Given this list of marker genes PRPH2, IMPG1, EYS, IDH3B, CRX, DHX38, DCN (decorin), PIEZO2, ZNF513, NR2F1, CC2D2A, GDF6, TUB, FGFR2, SLC4A11, GNB5, FAM161A, RP1L1, TOPORS, HGSNAT, CFAP418, IDH3A, PRDM5, AHI1, MAK, REEP6, TUBA3D, PCYT1A, LMX1B (NCBI Gene Id 4010), TULP1, VSX1, RLBP1, KLHL7, CA4, SPATA7, GUCY2D, AGBL5, SLC7A14, CNGB1, RPE65, RBP3, ABCA4 (NCBI Gene Id 7815), ROM1, KIZ, SEMA4A, AP1B1, ZEB1, IQCB1, ZNF408, GUCA1B, NRAS, CERKL, SCAPER, CDHR1, RGR, CHST6, USH2A, IFT172, MERTK, RP1, USP45, PRPF4, FGFR3, RDH12, GLI3, DDR2, NRL, BBS1 (Bardet-Biedl syndrome 1), ANTXR1, RP2, PLOD1, OFD1, PCARE, PRPF31, RP9, SNRNP200, PRPF6, PDE6A, KIAA1549, LRAT, CLRN1, TUBB4B, BEST1, IFT88, SAG, IMPG2, NEK2, ARL6, IMPDH1, KERA, MIR184, PDE6B, ZNF469, AIPL1, PDE6G, PRPF3, ARHGEF18, RD3, FGF10, CEP290, ITPR1, FSCN2, PRPF8, PRCD, PROM1, CHRDL1, NR2E3, ARL2BP, ARL3, DHDDS, NMNAT1, COL3A1, KCNJ13, AHR, CRB1, CNGA1, RHO, LCA5, TTC8, BBS2, IFT140, RPGR, RPGRIP1, HRAS, POMGNT1 (NCBI Gene Id 55624), SLC2A10, here is a description of the gene set: Human Gene Set: HP_ABNORMAL_CORNEAL_THICKNESS species: Homo sapiens Abnormal corneal thickness An abnormal anteroposterior thickness of the cornea.